The following is a description of a gene set: Mouse Gene Set: SOX15_TARGET_GENES studied in species Mus musculus Genes containing one or more binding sites for (Sox15) in their promoter regions (TSS -1000,+100 bp) as identified by GTRD version 20.06 ChIP-seq harmonization. from publication Yevshin I, Sharipov R, Kolmykov S, Kondrakhin Y, Kolpakov F (PMID 30445619), and this is the list of marker genes: Senp1, Gm10701, Gm16305, Lpp, Cp, Adamtsl4, Glis3, Mtus1, Met (NCBI Gene Id 194383), Gm28818, 2310081O03Rik, Tcf4, Sec61bl, Gm12530, Ptpn22, Slc13a4, Smurf1, Vdr, Fancc, C1qtnf1, Mpzl1, Eps8, Slc25a21, Aig1, Ltbp1, Gsto1, Gm15867, Cetn4, Kif21a, Sox6